The following is a description of a gene set: studied in species Homo sapiens Human Gene Set: GOBP_MITOTIC_CYTOKINETIC_PROCESS Any cytokinetic process that is involved in mitotic cell cycle., and this is the list of marker genes: ARF6, CEP55, CHMP2A, MTMR3, RAB11FIP3, ECT2, CHMP4A, MTMR4, CHMP3, VPS4A, CHMP7, RHOA, CHMP6, KLHDC8B, EXOC7, RAB11A, CHMP1A, IQGAP3, PDCD6IP, CHMP4B, IQGAP1, KIF20A, KIF20B, MITD1, CNTROB, SPART, ZFYVE19, IQGAP2, CHMP4BP1, AURKB, CHMP1B, NUP62, CHMP2B, CHMP5 (NCBI Gene Id 51612), ARF1, VPS4B, IST1, CHMP4C